Given this list of marker genes TRAK1, TRAK2 (trafficking kinesin protein 2), MFN2, RAP1GDS1, RHOT2 (ras homolog family member T2), RHOT1, MFN1, MYO19, here is a description of the gene set: part of: Signaling by Rho GTPases, Miro GTPases and RHOBTB3 species: Homo sapiens Miro GTPases are a separate family of Ras-related GTPases that are sometimes included in the atypical RHO GTPases group, but are phylogenetically distinct from the Rho family. Miro GTPases possess an additional GTPase domain more closely related to Rheb. Miro family of RAS-like GTPases includes two members, RHOT1 and RHOT2. RHOT1 and RHOT2 regulate the movement of mitochondria and peroxisomes. Reactome Pathway: Miro GTPase Cycle